The following is a description of a gene set: Transport of small molecules species: Homo sapiens Human Gene Set: REACTOME_TRANSPORT_OF_SMALL_MOLECULES, and this is the list of marker genes: ATP8B4, SLC6A6, SLC30A5, MIP, BSG, STOML3, SLC9B1, ATP6V1F, SLC16A1, PSMD6, MCU, SLC5A2, ESYT2, MICU2, TRPM1, CLCA1, ABCA3, ABCB4, CASQ1, MRS2, LETM1, PIP, LSR, SLCO4C1, TRPM3, TF, ATP2B4, SLC35A3, SLC28A2, SGK2, PSMD12, STEAP3, APOBR, TRPC5, ATP6V1B2, SLC12A3, SLC4A3, HBA1, TTYH2, SLC14A1, SLC3A1, SLC35C1, SLC16A10, FXYD7, SLC28A1, CP, HMOX2, VCP, AP2B1, ADCY4, SLCO1B1, DERL3, SLC15A1, ABCC2 (NCBI Gene Id 1244), PMPCA, TSC22D3, ASIC4, GNB5, SRI, PEX19 (peroxisomal biogenesis factor 19), ANO9, SLC7A9, FGF21, MBTPS2, ATP6V1G1, SLC30A10, SGK1, SLC2A7, RAB11FIP2, SLC35D2, UBC, AQP12A, ADD2, SLC22A12, ABCG4, PSMD14, ADCY2, APOC3, ATP6V1C1, SLC20A1, STOM, SCNN1G, SLC22A5, ATP6V1A, SOAT1, NIPAL1, TRPM4, FURIN, DERL2, CLCN3, SLC7A10, SLC22A8, SLC22A4, CAND1, CSN3, SLC17A6, ASIC5, SLC1A5, WNK4, GNG12, SLC24A5, DERL1, NIPA2, GNGT1, ATP13A1, PSMA6, BEST2, ATP6V1G3, SLC36A2, SLC6A9, SLC26A3, PSMC4, SLC26A2, SLC4A7, BEST4, SLN, ABCB10, SLC66A1, SLC8A2, SEM1, ABCC6, SLC25A1, SLC9A8, PRKAR2A, ABCC1, ABCC10, SLCO2A1, PSMB7, SLC34A1, SLC13A3, GNG13, GNB3, EIF2S1, BEST3, ASIC1, ATP9B, SOAT2, SLC9A2, ABCB9, SLC39A14, SCNN1D, P4HB, CYB5R1, APOA1 (apolipoprotein A1), ABCG8, MAIP1, PSMD3, ATP8A1, APOE, ADCY6, SLC5A11, ABCB7, ATP6V1E1, ATP8A2, CALM1, TRPV5, CLCN5, PSMA4, GNG10, SLC17A1, SLC9A3 (NCBI Gene Id 6550), ANO4, SLC24A4, RIPK1, WNK1, ATP1A2, TPCN2, PRKACA, CLTA, ADRM1, PSMC2, SLC2A2, SEL1L, SLC39A10, CTNS, SLC29A2, SLC15A4, ERLIN1 (ER lipid raft associated 1), AQP5 (aquaporin 5), ATP2C1, ATP8B3, FXYD2, SLC5A6, MTTP, PSMA2, SLC26A7, SAR1B, SCARB1, RAF1, TRPM2, FTL, ESYT3, ATP4A, STOML2, SLC45A3, SLC16A2, ATP6V1D, CLCN2, ALB, ATP6AP1, SLC6A13, SLC6A14, LCN15, SLC39A6, ANKH, FBXL5, PSMB2, SLC25A10 (NCBI Gene Id 1468), SLC9B2, FLVCR1, PSMB3, ATP6V1G2, SLC39A3, ASIC2, LRRC8C, SLC5A3, ABCC11, CFTR, ASIC3, AKAP1, ATP6V1C2, SLC22A18, PSMB5, MCUB, SLC35B4, SLC6A1, CYB5R2, PRKAR1B, CLCN7, LPL, PCSK5, ATP6V0B, SLC18A2, GNG8, SLC13A1 (solute carrier family 13 member 1), SLC11A2, SLC26A9, ATP6V0E1, SLC6A7 (solute carrier family 6 member 7), APOA4, SLC30A3, AQP11 (aquaporin 11), SLC6A12, TRPC7, AP2A2, RYR2, ERLEC1, ATP6V1H, ADD3, SLC35B3, ABCA5, MCOLN1, LDLRAP1, PSMD13, SLC25A11, AQP1, APOD, SLC30A1, CAMK2G, ATP1B1, ABCB8, AVP, AFG3L2, RNF185 (NCBI Gene Id 91445), SLC39A4, AQP3, CPTP, VDAC1, ABCD2, ATP7A, ATP1A4, SLC12A7, PSMC1, SLC44A5, SLC7A11, ATP6V0A1, SLC44A3, SLC1A4 (NCBI Gene Id 6509), FXYD6, ADCY7, CLCA4, SLC2A3, SLC17A5, SLC13A4, ATP2A2, SLC35A2, GNG7, CYB5RL, LDLR, SLC26A1, LMF2, CLCNKB, ABCG5, MICU1, AZGP1, SLC22A3, TRPC4, ADCY9, PARL, NIPA1, SLC31A1, ABCC5, WWP1 (WW domain containing E3 ubiquitin protein ligase 1), CLIC2, SMDT1, RIPK3, GNB2, SLC1A3, SLC6A3, ATP6V0D2, SLC5A12 (solute carrier family 5 member 12), NEDD8, PSMD11, SLC1A6, PCSK6, TRPC3, SLC26A6, SLC4A2, VDAC2, WNK3, SLC44A1, APOF, SLC25A4, SLC2A8, SLC22A7, SLC5A8, SLC15A3, ARF1, SLC26A4, ADCY8, SLC9A6, LRRC8B, CREB3L3, ATP13A5 (NCBI Gene Id 344905), ATP11A, SLC44A2, TRPM6, CYGB, SLC36A4, SLC8A1, ATP12A, SLC41A1, CA4, SLC6A15, SLC12A2, PSMC3, PLEKHA8, ESYT1, SLC27A4, PSMC5 (proteasome 26S subunit, ATPase 5), TRPV4, FTMT (NCBI Gene Id 94033), SLC6A18, PSMC6, TTYH1, FKBP1B, ZDHHC8 (NCBI Gene Id 29801), ANGPTL4, PHB2, SLC4A5, ABCA2, CLCNKA, SLC38A1, SLC16A7, FXYD1, CIDEC, WNK2, PSMD7, LCN1, MICU3, SLC2A14, SLC4A1, ABCA1, AQP4, CUTC, SLC6A5, NALCN, LRRC8E, PLTP, SLC9A1, ANO2, SLC20A2, SLC5A7, AQP9, SLC36A1 (solute carrier family 36 member 1), GNB1, SLC7A2, OSTM1, CLCA2, SLC2A4, SLC25A29, CUBN, SLC9A4, SLC4A4, ANO3, SLC39A8, SLC17A3, SLC2A12, SLC25A22, EIF2S2 (NCBI Gene Id 9359), ATP2C2, RHBG, ABCD1, SLC13A5, SLC35D1, FTH1, PLN, RUNX1, SLCO4A1, APOA5, HBB, RYR3, AP2A1, TRPC6, MYLIP, MFSD4B, SLC41A2, SLC38A4, SLC22A17, UBB, RHAG, TRPV3, LIPG, SLC5A5, SLC22A15, NCEH1, SLC2A9, TRPM5, SLC7A1, SLC22A11, GLRX3, ATP9A, SLC6A20, ABCF1, VLDLR, SLC16A3, ABCC4, SLC8A3, NR1H3, PCSK9, GNG4, SLC38A2, ATP6V0C, ERLIN2, PSMD1 (proteasome 26S subunit, non-ATPase 1), AMN (amnion associated transmembrane protein), CLN3, SLC2A10, SLCO1B3, MCOLN2, TCIRG1 (NCBI Gene Id 8845), CAMK2D, LCN12, SLC9A7, HDLBP, NPC1, ATP13A2, SLC39A5, MB, SLC7A8, SLC2A6, SLC1A1, BEST1, PSMD2, SLC7A3, UNC79, A2M, SLC2A11, ADCY1, ATP13A4, RNF5, ANO6, AP2M1, SLC34A2, SLC39A2, GNG3, ATP10B, CSN1S1, CASQ2, CUL1, SLC24A2, CYB5R4, SLC39A1, KCNJ11 (potassium inwardly rectifying channel subfamily J member 11), SLC34A3, ABCB5, SLC8B1, ATP11C, MMGT1, OS9, SLC29A1, CES3 (carboxylesterase 3), SGK3, GNAS (GNAS complex locus), GNB4, ARL2, ABCA12, MLKL, LRRC8A, TUSC3, PSMB4, GNGT2, GPIHBP1, TRPV1, SLC13A2, TRPC4AP, TFR2, SLCO1A2, GLTP, ANO7, ADCY5, CYBRD1, ATP7B, HMOX1, PSMD8, ATP1B3, HBA2, SLC44A4, LMF1, LIPC, SLC4A10, ABCG2, SLCO2B1 (NCBI Gene Id 11309), PSMA3, SLC14A2 (NCBI Gene Id 8170), AVPR2, SLC18A1, EIF2S3, SLC17A8, FXYD3, DMTN, ABCB6, EMB, ABCA10, SLC5A9, ATP2B2, LCN2, SLC6A11, SLC11A1, SLC29A4, SLC6A19, RAB11A, APOC4, TRDN, SLC30A2, CLCN1, LCN9 (NCBI Gene Id 392399), VDAC3, CA1, MAGT1, SLC29A3, ANGPTL3, NIPAL2, SLC17A7, ANGPTL8, SLC26A11, ATP2A1, PRKAR1A, TRPM7, ANO1, SLC7A7 (solute carrier family 7 member 7), ATP6V0D1, PSMB1, SLC39A7, SLCO3A1, ATP6V0A2, CETP, SLC40A1, SLC43A2, STEAP4, SLC2A13, GNG11 (NCBI Gene Id 2791), NR1H2, UBA52, SLC38A5, SLC46A1, SLC24A3, ABCA8, LCAT, ANO5, TRPV2, SCNN1B, CAMK2A, ATP6V1B1, ATP6V0A4, SLC28A3, NIPAL3, ABCB1, YME1L1, SLC22A2, ARL2BP, ATP2B3, AQP6 (NCBI Gene Id 363), CLTC, PSMA7, NEDD4L, IREB2, MYO5B, ATP10A (NCBI Gene Id 57194), ATP6V0E2, ABCA6, SLC9A9, ACO1, SLC27A6, LIPA, GNG5, SLC25A6 (solute carrier family 25 member 6), SLC27A1, LRRC8D, RPS27A, ATP10D, ABCA4, SLC50A1, SLC4A8, SLC9C1, AHCYL2, UNC80, ATP2B1, ABCD3, ABCC9, AQP8, ADD1, NGB, NPC2, SLC22A1, SLCO1C1, SLC7A5, SLC47A1, SLC43A1, PRKAR2B, SLC24A1, ATP1A3, SLC12A1, ATP2A3 (ATPase sarcoplasmic/endoplasmic reticulum Ca2+ transporting 3), ANO8, APOB, SLC22A6, SLC6A2, ASPH, SLC32A1, NIPAL4, PSMA1, ATP8B1, SLC9A5, ATP4B, SLC5A10, SLC1A7, RHCG, SLC25A26, AQP7, TFRC, SLC33A1, ABCG1, RYR1, SLC4A9, CLCN6, PRKACB, PSMA5, ATP1A1, TRPA1, SKP1, SLC35A1, SLC25A18 (solute carrier family 25 member 18), SLC9C2, PEX3, SLC10A6, MBTPS1, BMP1, SLC1A2, SLC47A2, TRPC1, GNG2, SLC12A4, PRKACG, SLC38A3, ABCA7, APOA2, LPA, AQP10, SLC12A6, APOC2, SCNN1A, SLC5A1, TRPM8, CAMK2B, HFE, CA2 (NCBI Gene Id 760), BSND, TTYH3, APOC1, SPG7, AQP2, TRPV6, FXYD4, SLC2A1, SLC35B2, PSMB6, ATP1B2, SLC30A8, ABCC3, PHB1 (NCBI Gene Id 5245), SLC16A8, CLCN4, SLC7A6, ATP11B, RSC1A1, SLC5A4, ADCY3, ABCA9, SLC12A5, SLC22A16, HEPH, PMPCB (NCBI Gene Id 9512), PDZD11, ATP6V1E2, MCOLN3, TPCN1, SLC25A5, ANO10, ATP8B2, AP2S1, SLC3A2